Given this list of marker genes CD300LF, TLR1, ZMYND15, GAPT, TICAM2, NPL, MGST1, CD14 (CD14 molecule), FPR3, here is a description of the gene set: species: Homo sapiens A better understanding of the relationships between vaccine, immunogenicity and protection from disease would greatly facilitate vaccine development. Modified vaccinia virus Ankara expressing antigen 85A (MVA85A) is a novel tuberculosis vaccine candidate designed to enhance responses induced by BCG. Antigen-specific interferon-gamma (IFN-gamma) production is greatly enhanced by MVA85A, however the variability between healthy individuals is extensive. In this study we have sought to characterize the early changes in gene expression in humans following vaccination with MVA85A and relate these to long-term immunogenicity. Two days post-vaccination, MVA85A induces a strong interferon and inflammatory response. Separating volunteers into high and low responders on the basis of T cell responses to 85A peptides measured during the trial, an expansion of circulating CD4+ CD25+ Foxp3+ cells is seen in low but not high responders. Additionally, high levels of Toll-like Receptor (TLR) 1 on day of vaccination are associated with an increased response to antigen 85A. In a classification model, combined expression levels of TLR1, TICAM2 and CD14 on day of vaccination and CTLA4 and IL2Ralpha two days post-vaccination can classify high and low responders with over 80% accuracy. Furthermore, administering MVA85A in mice with anti-TLR2 antibodies may abrogate high responses, and neutralising antibodies to TLRs 1, 2 or 6 or HMGB1 decrease CXCL2 production during in vitro stimulation with MVA85A. HMGB1 is released into the supernatant following atimulation with MVA85A and we propose this signal may be the trigger activating the TLR pathway. This study suggests an important role for an endogenous ligand in innate sensing of MVA and demonstrates the importance of pattern recognition receptors and regulatory T cell responses in determining the magnitude of the antigen specific immune response to vaccination with MVA85A in humans. Genes up-regulated in peripheral blood mononuclear cell high responders vs low responders in adult (18-55) after exposure to Modified Vaccinia Ankara (MVA) virus vaccine vector, time point 0D. Comment: genes part of classifier from publication Matsumiya M, Stylianou E, Griffiths K, Lang Z, Meyer J, Harris SA, Rowland R, Minassian AM, Pathan AA, Fletcher H, McShane H (PMID 23844129) Human Gene Set: MATSUMIYA_PBMC_MODIFIED_VACCINIA_ANKARA_VACCINE_AGE_18_55YO_HIGH_RESPONDERS_VS_LOW_RESPONDERS_0DY_UP